The following is a description of a gene set: The appearance of transforming growth factor-beta1 due to biosynthesis or secretion following a cellular stimulus, resulting in an increase in its intracellular or extracellular levels. Mouse Gene Set: GOBP_TRANSFORMING_GROWTH_FACTOR_BETA1_PRODUCTION studied in species Mus musculus, and this is the list of marker genes: Col3a1, Lum, Atp6ap2, Gata6, Foxp3, Tyrobp, Cd2ap, Furin, Cx3cl1, Serpinb7, Tsku, Laptm4b